Given this list of marker genes VEGFB, VEGFA, SWAP70, RIN3, VEGFD, PGF (placental growth factor), RAC2, VEGFC, here is a description of the gene set: Any process that modulates the rate, frequency or extent of mast cell chemotaxis. Mast cell chemotaxis is the movement of a mast cell in response to an external stimulus. Human Gene Set: GOBP_REGULATION_OF_MAST_CELL_CHEMOTAXIS species: Homo sapiens